Given this list of marker genes ENSG00000261436, ADGRG3, POLR2C, CKLF, BEAN1, SETD6, CNOT1, PPIAP48, HMGB3P32, RNU6-21P, CDH8-AS1, APOOP5, RNU6-20P, RPS15AP34, TIPINP2, LINC02141, GOT2, RNU6-103P, ENSG00000304793, DUXAP11, RPL23AP91, LINC02165, CIAPIN1, CDH8, MMP15, DOK4, KIFC3, CFAP20, GNPATP, CCL22, PRSS54, ENSG00000187185, CX3CL1, SNORA46, RN7SKP76, CSNK2A2, COQ9, DRC7, RPL12P36, LINC00922, ADGRG5, GINS3, RNU6-269P, LINC02126, CDH5, CDH11 (cadherin 11), SLC38A7, MTCH2P3, CFAP263, RN7SL143P, ADGRG1, LINC02137, NDRG4, SPMIP8, RNU4-58P, CMTM1, CCDC102A, USB1, DPPA3P11, SNORA50A, RN7SL645P, RNA5SP428 (NCBI Gene Id 100873679), RPS27AP16, BEAN1-AS1, CNGB1, NPAP1L, CMTM2, RNU6-1110P, RNU6-1155P, GEMIN8P2, MIR6772, TK2, CCL17, RPS27P27, UBE2FP2, KATNB1, CKLF-CMTM1, ZNF319, LINC00920 (long intergenic non-protein coding RNA 920), ENSG00000261638, here is a description of the gene set: Human Gene Set: chr16q21 studied in species Homo sapiens